Given this list of marker genes SLC8A1, NFAT5, DANT2, NEDD4L, SDK1, CD2AP, HIF1A (NCBI Gene Id 3091), UBC, UBE2H, PDE4D, DYRK1A, PFKFB3, MAGI3, KIAA1217, THSD4, AFF4, EPB41L5, NR3C2, MLF1, ATXN1, STAT3, AFF1, ERC1, EZR, EMCN, RAPGEF2, MEF2A, UACA, DCDC2, TOX, RAP1B, CCNL1, BACH2, ARL15 (ADP ribosylation factor like GTPase 15), SCN2A, SIK2, ATF3, MACC1, SMARCA2, LRP1B (NCBI Gene Id 55424), MSMO1, WWC1, GAREM1, ZFP36, LGALS3, ATP1B3, ST6GAL1, ITGAV, PDK4, NEAT1, FHOD3, RBPMS, ARHGEF12 (NCBI Gene Id 55406), PRKAG2, NLK, CSGALNACT1, MAPK8, MIR4435-2HG, IL6ST, NOS1AP, ZFAND3, MYO1E, RORA, DDIT3, ZNF704, SH3RF1, SAT1, WSB1, INSIG1, BACH1 (BTB domain and CNC homolog 1), KIF13B, MYO10, PRKCA, AAK1, WWTR1, TEX41, PRKCE, SGPP1, HSD11B2, AKT3, SLC38A1, HLA-E, ESYT2, BMPR1B, TOP1, JMJD1C, LRRFIP1, MYO1B, ACTG1, ADK, RAD51B, NR4A1, KRT19, TSC22D2, PPARGC1A, FRAS1, RALGAPA1, BCAS3, MACROD2, ZNF165, NPC1, FNIP2, FER, HSPH1, GLS, LIMA1 (LIM domain and actin binding 1), HSPA5, BTG2, ANK3, FOS, SLC19A2, ABLIM1, ZNF292, ZSWIM6, ARID1B, MTATP6P1, FOSB, SHROOM3, IGFBP5 (insulin like growth factor binding protein 5), FAM110B, TPST1, GRIP1, RAB7A, TNFRSF10B, MPPED2, KLF6 (NCBI Gene Id 8025), SPAG9, XIST, DUSP1, MCU, BACE2, RTN4, EXT1, TMEM51, MAP4K3 (mitogen-activated protein kinase kinase kinase kinase 3), ADGRL2, LAMB1, RBM47, ASAP2, VCL, MID1, MYO1D, HSP90B1, PALLD, PRKN (parkin RBR E3 ubiquitin protein ligase), ACSL4, DNAJB1, MECOM, GAB1, BTBD9, LMNA, PIK3C2G, DNAJA1, ZFAND5, COBLL1, GLIS3, TRPS1, PRKG1, IQGAP1, RALYL, IMMP2L, ITGA2, RNF19A, TIMP3, AGBL4, SCIN, MAML3, SREBF2 (NCBI Gene Id 6721), MAP3K14, TRA2A, JUN, SMYD3 (SET and MYND domain containing 3), IDI1, TMTC2, YWHAZ, ARIH1, MED13L, CRY1 (NCBI Gene Id 1407), AHNAK, SQSTM1, NCOA7, RANBP2, OSBPL3 (NCBI Gene Id 26031), UPP1, TANC2, NFE2L2 (NCBI Gene Id 4780), HIVEP2, PWRN1, FHIP1A, HERC1, TJP1, NDRG1, YBX3, BRAF, ELF3, PCDH9, SAMD12, NAMPT, TRAK1, ACTN4, NAALADL2 (N-acetylated alpha-linked acidic dipeptidase like 2), HNRNPC, SPTBN1 (spectrin beta, non-erythrocytic 1), CLMN, DLG2, SSH2, FNDC3A, CAST, PAWR, EGR1, GPX3, ABTB2, CCSER1, TPM4, SIK3, QKI, FBXL17, ELOVL5, MTUS1, DEFB1, SLC25A25, UBE2D3, EIF2AK3, HSPA1A, VMP1, ALDOB, LINC-PINT, ERBB4, IFRD1, AHI1, ADAMTS9-AS2, COL18A1, CADPS2, LDLR, NFKBIZ, NEK1, GDF15, HMGCS1, MBD5, C4orf19, here is a description of the gene set: Human Gene Set: LAKE_ADULT_KIDNEY_C17_COLLECTING_SYSTEM_PCS_STRESSED_DISSOC_SUBSET from publication Lake BB, Chen S, Hoshi M, Plongthongkum N, Salamon D, Knoten A, Vijayan A, Venkatesh R, Kim EH, Gao D, Gaut J, Zhang K, Jain S (PMID 31249312) studied in species Homo sapiens